Given this list of marker genes TBC1D24, PXMP4, UROD, ELP6, ACTL6A, MICOS10, ITPA, RNGTT, BIVM, POP5, TRMT1, ZCCHC17, ROGDI (NCBI Gene Id 79641), DYRK2, DHX29, VASH1, WDR1, PRPF31, MRPS6, AP3D1, POLD2, PDIK1L, PRKAR2A, NSFL1C, FLVCR2, GATD3, MSH2, CHCHD7, PIN4, MYC, ASL, DCAF13, URB2, CARNMT1, SENP3, IL16, HEATR1, SLC25A12, PAQR4, ABHD15, MTFR2, DDX28, WDR37, MRPL24, MRS2, PLEKHJ1, PLEKHO2, NINJ2, TMEM273, COA5, RELL1, CCT6A (NCBI Gene Id 908), GMFB, FES, SLC18A2, SCFD2, COMMD8, PRPS2, GAR1, DHX15, FAM78A, SNX4, ABAT, TRIM32, SPDL1, PDE6D, CWC27, USP46, EIPR1, GATC, DCAF4, PCYOX1L, GLCE, HDAC1, HNRNPM, PHAX (phosphorylated adaptor for RNA export), INTS8, UMPS, CTR9, SLC12A6, SLC17A9, KIAA0586, DHFR, SHPRH, RUVBL2, SF3A3, SNUPN, PSMD2, CRH, TRIM37, PTPN11, NDUFAB1, TUBB6, ZNF35, ZNF319, ARB2A, CLSTN1, GLMN, MTFMT, GTF2A2, NARS1, P2RY13, PTK2, NAGPA, SETBP1, HENMT1, ATP11A, ZYG11B, ANKMY2, TRAPPC12, AP2A2, FRMD4A, PDCD6, TMTC4, PRORP, TARDBP, MAF (MAF bZIP transcription factor), MRM2, EBNA1BP2, LSG1, RFC5, FAM98B, FKBP14, VRK1, ANKRD16, TP53RK, LARP4, ENDOG, SLC36A1, COA4, PNP, CEP85L (NCBI Gene Id 387119), NUDT6, TOPBP1, MAP7, RNF166, NDUFAF4, HSBP1, TIAM1, HAUS6, TFAM, SUOX (sulfite oxidase), RAPH1, ZNF559, PSMG4, BTBD1, RANBP1, TEFM, NME6, CCDC51, NCOR2, RFC3, MRPL20, ATP2A2, PITPNA, SKA2, HECTD1, RLIG1, DELE1, GTF3C2, CCT4, NAA38, MTRES1 (mitochondrial transcription rescue factor 1), NUDT5, PCSK7, PEX1, DOK2, LIMA1, VPS36, GPATCH1, PRDM15, PCYOX1, MRPL58, SMARCAD1, METTL25, IPO11 (importin 11), PRPF38B, MRI1, CFAP298, ATP5PF, CTSC, RCAN3 (RCAN family member 3), POLR2B, LMNB2, DDX46, POLR1E, LBHD1, ZBTB33, TIMM50, NLRP2, G2E3, ZNF789, EIF4EBP2, SAMM50, ZNF641, ORC5, DHX30, DNAAF5, UNG, here is a description of the gene set: species: Homo sapiens Human Gene Set: GSE18791_CTRL_VS_NEWCASTLE_VIRUS_DC_16H_UP from publication Zaslavsky E, Hershberg U, Seto J, Pham AM, Marquez S, Duke JL, Wetmur JG, Tenoever BR, Sealfon SC, Kleinstein SH (PMID 20164420) The dendritic cell (DC) is a master regulator of immune responses. Pathogenic viruses subvert normal immune function in DCs through the expression of immune antagonists. Understanding how these antagonists interact with the host immune system requires knowledge of the underlying genetic regulatory network that operates during an uninhibited antiviral response. In order to isolate and identify this network, we studied DCs infected with Newcastle Disease Virus (NDV), which is able to stimulate innate immunity and DC maturation through activation of RIG-I signaling, but lacks the ability to evade the human interferon response. To analyze this experimental model, we developed a new approach integrating genome-wide expression kinetics and time-dependent promoter analysis. We found that the genetic program underlying the antiviral cell state transition during the first 18-hours post-infection could be explained by a single regulatory network. Gene expression changes were driven by a step-wise multi-factor cascading control mechanism, where the specific transcription factors controlling expression changed over time. Within this network, most individual genes are regulated by multiple factors, indicating robustness against virus-encoded immune evasion genes. In addition to effectively recapitulating current biological knowledge, we predicted, and validated experimentally, antiviral roles for several novel transcription factors. More generally, our results show how a genetic program can be temporally controlled through a single regulatory network to achieve the large-scale genetic reprogramming characteristic of cell state transitions. Genes up-regulated in comparison of control conventional dendritic cells (cDC) at 0 h versus cDCs infected with Newcastle disease virus (NDV) at 16 h.